Given this list of marker genes TCF20, PACSIN1, IRS3P, MPPED1, OTOP1, KHDC3L (KH domain containing 3 like, subcortical maternal complex member), RELN, FOXD4, PTPRT, TCTE1, VAX1, RAPGEF4, KCNIP1, SCT, TNNI3, NTRK3, SORCS3, MMP24, DOC2A, VSTM2A, NRG3, OTOP3, CLDN4, PHOX2A, CRYM, NAGS, WNT10A, TFAP2D, KCNQ3, KL, LBX1, ELOVL3, NKX2-2, TULP1, SIX6, KCNH5, GHSR, ECEL1, FERD3L, POU2F3, CSPG5, MYOD1, KCNA2, PLK5, FBLL1, KCNB1, AQP5, CDH8, PLEKHG6, GAL, ELFN2, NKX6-1, DMRTC2, TTC9B, CADM3, FAM163A (NCBI Gene Id 91000), NGB, TMPRSS2, KCNH1, GPR26, SELENOV, RAB37, IGSF21, IKZF1, CHD5, RASGRP2, PSD2, CHRNA4, TBX20 (T-box transcription factor 20), LIN28A (NCBI Gene Id 79727), CHGB, DISP3, DLEU7, LRRC26, SEZ6L, BRSK2, CYP4F22, IGFBPL1, HES3, DKKL1, CNTN2, PRRT3, AMN, CYP27B1, TBXT, ZNF804A, ALX1, SLC6A1, ONECUT2, DLL3, OXT, SKAP1, INSM1, LHX5, NELL1, SKOR1, KLHL14 (NCBI Gene Id 57565), C1QL2, CALCR, SLC35F3, GRM1, NKX2-8, PHOX2B, UGT8, KCNJ10, LMX1A, KCNQ2, OPRD1, THBS4, ASIC4 (acid sensing ion channel subunit family member 4), SPAG6, PSD, SVOP, RAP1GAP2, BOLL, AJM1, GRID1, ALOX15, CALB1, MAL, KIF12, SLC26A5, KCNH8, RIMKLA, HMX2, PYY, ACAA1, TFAP2B, PRDM14, HCN1, SCN3B, FGF11, GRIA2, CPLX2, CHAT, PCDH8, CPLX1, CYP24A1, SLC15A1, DIRAS1, OTUD7A, POU3F2, TCF15, DRD2, CD70, CACNA2D2 (calcium voltage-gated channel auxiliary subunit alpha2delta 2), HTRA3, PAQR6, AQP3, SLC5A8, SOX1, UNC5A, NRTN, POU4F1, FAM163B, WSCD1, GRIN2A, IRF6, GSX1, PHACTR3, SCN8A, FEV, FEZF2, BICDL1, DES, TMEM181, GPR12 (NCBI Gene Id 283535), GRIK3, DMBX1, FOXB1, SLC46A2, DSCAML1, SST, RBMXL2, NRXN2, TMEM130, MFSD6L, SCRT1, SLC12A5, TMEM150C, NKX1-2, KCND3, PHACTR1, LHFPL4, ATP2B2, HAND1, LHFPL5, LRFN5, SLC22A3, PRDM8, GABRG3, IHH, KCNA7, TMEM229A, OLIG1, LINGO3, GP1BB, SLC5A1, PRKCZ, NEUROD1, KDF1, SHE, CDCP1, RAX, GRK3, SLC18A2, PAX7, DPYS, ALOX12, PRRT1, HOXD4, EMILIN3, NMU, CARTPT, CNNM1, NEUROG1, KCNS2, CHRNB2, GSX2, TUBB4A, WNT9B, TACSTD2, SYNDIG1L, TMEM59L, TEKT4, RASAL1, ADAM11, SYT10, ATP8B3, KCNH7, JPH3, SLC6A11, TCF21, ACAN (NCBI Gene Id 404712), ATP8A2, SHISA6, SCN5A, TMEM171, CAMK2B, CCDC92B, DLGAP2, FGF14 (fibroblast growth factor 14), GRIN2C, BCAN, FGF20, LY6H, PCNX2, ZNRF4, HTR1A (5-hydroxytryptamine receptor 1A), NKX6-2, CDX1, MARVELD3, AATK, SLC17A6, FGF12, LRAT, CHRNA3, NECAB2, LAMC2, GRIN3B, CA10, JHY, PADI2, HTR4, MOS, SLC30A2, ZMAT4, RFX4, LAMC3, KCNQ1, CDX2, SERTM1, LRTM2, NTSR1, STMN3 (stathmin 3), HOXB1, TACR1, CELSR1, KNDC1, CBLN2, LARGE2, ST8SIA3, NRROS, SYPL2, GAD1, PIK3CD, PNMT, SGSM1, SNCB, AMER3, SLC6A5, WNT3A, SLC34A2, UNCX, PPM1N, MAST1, KCNS1, LSR, AP1M2, SSTR5, SOX18, SIX3, CWH43, IKZF3, GALR1, FCHO1, PRLR, FFAR4, CPN1, ELAVL2, LEFTY2, MYRIP, DNAJC22, POU4F3, SEL1L3, NR2E1, SPRN, KCNC1, HRK, APOA5, GOLGA7B, GSTT2, THEMIS2, GJB6, CDK5R2, SHH, SLC6A7, GPRIN1, TRH, NHLH2, NPAS1, TNFRSF9, JAG2, MMD2, RUNDC3A, HOXB3, SCNN1B, SLC45A1 (NCBI Gene Id 50651), DSC2, SLC13A3, ACP7, SALL4, EPHA6, CPNE7, ADGRB1, EPHX3, TTYH1 (NCBI Gene Id 57348), TTC22, NXPH1, WNT7A, FOXG1, PLBD1, POU4F2, IRX4, GABRA5, SCGN, TMEM179, CRHBP, GALNT6, ABCC8, TNXB, DCC, ADGRB3, FGF17, SLITRK3, TAFA3, C14orf39, SLC32A1, OXTR, SNHG11, FOXL1, APBA2, TFAP2E, CD164L2, BHLHE23, STK32B, IL10RA, GNG13, PFN3, GRHL2, DSG2, CA4 (NCBI Gene Id 762), GJD2, CABP7, NETO1, SLC27A2, LYPD3, CHGA, PLIN5, PLPP4, ATP1A3, MYO5C, CIMAP1B, KCNT1, EXOC3L2, PPP2R2C, SLC47A1, SCUBE1, WNT4 (NCBI Gene Id 54361), CBLC, SHTN1, TBX21, PTPRN2 (NCBI Gene Id 5799), RBPJL, PAX1, CPNE9, CIMIP2C, GRHL3, SLCO4C1, RHCG, SLC6A20, CNTN4, FNDC5, KY, TMEM91, GRP, OLFML2A, PPP1R16B, FSTL4, SLC7A14, KCNJ6, CRTAC1, IQSEC3, ACTL6B, RASEF, AARD (NCBI Gene Id 441376), FOXA2, DOC2B, RYR2, TFAP2C, CRACR2B, LHX3, VSTM2B (NCBI Gene Id 342865), CRHR1, NEUROD2, KRT83, EMX1, NKX2-1, HRH1, DPP10, ASTN1, CPXM2, MARCHF4, RASGEF1C, PTGDR, ACSL6, INSL3 (NCBI Gene Id 6020), NTM, LRRC9, SLC6A2, VWC2, CSMD1, HMX1, FGFR4, KCNC3, VSX2 (NCBI Gene Id 338917, visual system homeobox 2), RSPO4, POU3F3, CDH20, LAD1, TLX3, GFRA3, CACNA1E, RAB11FIP4, GLP1R, LRRC3B, OTP, GPR4, FGF3, DMGDH, NKX2-3, FOXD3, ALOX12B, HBZ, CNFN, SLC5A5, MATN4, TMEM114, FGF4, RSPO1, SLC7A10, BARX1, ATP12A, ALK, SRRM4, C1QL1, CPZ, PAQR5, MPZL2, FOXN4, BMP8B, UCN, GFI1, SLC16A11, EPHA8, LYPD4, DHH, NCMAP, DMRT1, AVP, DOK7, LUZP2, BHMT2, LAMP5, TDH, SFRP5, PDX1, DEGS2, PRR36, HOXC13 (NCBI Gene Id 3229), OLIG2, KCNV1, DMRT3, PRSS50, DCLK3, VSX1, TACR3, SNAP25, HRH2, HES2, MGAT5B, NKX2-5, PAX8, GATA5, SYT7, ACTN2, SRCIN1, HES5, CALB2, LGI2, PROM2 (NCBI Gene Id 200480), SRD5A2, NALF2, FAM43B, TCERG1L, CCKBR, EEF1A2, ADRA2C, DNAJC6, SLC9A3, FBP1, ONECUT3, B3GALT5, SPOCK1, MCF2L, DSCAM, QRFPR, RBFOX3, TRPM3 (NCBI Gene Id 80036), TMEM174, ACHE, C1QTNF4, TMEM215, ALOX5, SCTR, PTF1A, NPY5R, INSM2, BARHL2, NPHS2, NR4A3, CRB3, PRMT8, DBX1, SLIT1, SPTBN2, FOXE3, KCNA5, HS3ST2, SLC8A2, SOWAHA, ADRA1A, TAL1, CRH, CELF4, TLX1, NEUROG3, SOX2, PHF24, AIFM3, CLDN6 (claudin 6), MTARC1, BSN, CBLN4, LBX2, BARHL1, ADCYAP1, MMP9, OLIG3, WNT7B, MAPK8IP2, here is a description of the gene set: Human Gene Set: MIKKELSEN_MEF_HCP_WITH_H3K27ME3 We report the application of single-molecule-based sequencing technology for high-throughput profiling of histone modifications in mammalian cells. By obtaining over four billion bases of sequence from chromatin immunoprecipitated DNA, we generated genome-wide chromatin-state maps of mouse embryonic stem cells, neural progenitor cells and embryonic fibroblasts. We find that lysine 4 and lysine 27 trimethylation effectively discriminates genes that are expressed, poised for expression, or stably repressed, and therefore reflect cell state and lineage potential. Lysine 36 trimethylation marks primary coding and non-coding transcripts, facilitating gene annotation. Trimethylation of lysine 9 and lysine 20 is detected at satellite, telomeric and active long-terminal repeats, and can spread into proximal unique sequences. Lysine 4 and lysine 9 trimethylation marks imprinting control regions. Finally, we show that chromatin state can be read in an allele-specific manner by using single nucleotide polymorphisms. This study provides a framework for the application of comprehensive chromatin profiling towards characterization of diverse mammalian cell populations. from publication Mikkelsen TS, Ku M, Jaffe DB, Issac B, Lieberman E, Giannoukos G, Alvarez P, Brockman W, Kim TK, Koche RP, Lee W, Mendenhall E, O'Donovan A, Presser A, Russ C, Xie X, Meissner A, Wernig M, Jaenisch R, Nusbaum C, Lander ES, Bernstein BE (PMID 17603471) species: Mus musculus Genes with high-CpG-density promoters (HCP) bearing histone H3 trimethylation mark at K27 (H3K27me3) in MEF cells (embryonic fibroblast).